The following is a description of a gene set: species: Mus musculus from publication Chen Y, Wang X (PMID 31504780) Genes predicted to be targets of miRBase v22 microRNA mmu_miR_1194 in miRDB v6.0 with MirTarget v4 prediction scores > 80 (high confidence targets). Mouse Gene Set: MIR_1194, and this is the list of marker genes: A1cf, C1qtnf3, Slc41a1, Tomm20l, Sephs1, Spire1, Mark1, Rab11fip2, Nkain2, Zfp831, Cyp1a2, Ap2b1, Themis, Ube2d1, Itga1, Pakap, Ankib1, Foxn3, Vmn1r32, Ccdc88a, Igf1r, Erbin, Cd209a, Ndufa6, Brwd3, Sh2b1, Ammecr1l, Mfsd6, Uhrf2, Ubxn2a (NCBI Gene Id 217379), Mbnl2, Lrrtm3, Rsu1, Shisa6, Abtb2, Kbtbd8, Zfp69, Iqch, Nars1, Slc16a2, Vsnl1, Nova1, Mamdc2, Rap1a, Ppp1r2, Mgat2, Tab3, Med15, Epdr1 (NCBI Gene Id 94228), Sema5a, Tle4, Saxo2, Rab23, Prex2, Dipk1a, Fdx1, A4gnt, Xpo1, Siah1a, Mixl1, Tank, Nlgn1, Hgf, Dok1, Slc25a24 (solute carrier family 25 (mitochondrial carrier, phosphate carrier), member 24), Gria2, D16Ertd472e, Irf1